Given this list of marker genes MIR509-2, ENSG00000284377, MIR513A1, MIR509-1, SPANXA2-OT1, RN7SKP81, SOX3, FMR1, SLITRK2, MIR892A, SRD5A1P1, MIR510, MIR513B, CDR1, CXorf51B, MIR514A1, HNRNPA3P3, ENSG00000238485, SPANXN4, RPS17P17, CYCSP44, MTND1P33, HNRNPCP10, FMR1-AS1, MIR514A2, ANKRD11P2, MIR891A, MIR514B, RN7SKP189, HAPSTR2, ATP11C, FGF13, LDOC1, SPANXD, SPANXC, ELL2P4, MAGEC1, SNURFL, CXorf66, MIR888, MIR508 (NCBI Gene Id 574513), PGBD4P6, HNRNPH1P2, RNA5SP517, RNA5SP516, MIR514A3, RNU6-3P, MIR509-3, FMR1-IT1, MIR320D2, SLITRK4, CXorf51A, RNU6ATAC23P, NDUFB3P5, SPANXN1, RBMX2P2, MIR892C, TRMT1P1, MTND2P39, MIR507, RRM2P4, EEDP1, RN7SKP149, ENSG00000275268 (NCBI Gene Id 124905265), UBE2NL, RPL36AP52, MIR513C, RN7SL727P, LINC00632, MIR505, FMR1NB, MAGEC2, ENSG00000223438, F9, SPANXB1, MIR892B, MAGEC3, SPANXA1, SPANXN2, MIR891B (NCBI Gene Id 100126304), RNU6-382P, SPANXN3, MIR513A2, SPANXA2, MCF2, SLIRPP1, UFM1P1, MIR890, MIR506, here is a description of the gene set: species: Homo sapiens Human Gene Set: chrXq27